The following is a description of a gene set: from publication Qiu S, He P, Fang X, Tong H, Lv J, Liu J, Zhang L, Zhai X, Wang L, Hu Z, Yu Y (PMID 29580160) Individuals fail to elicit protective antibody after hepatitis B vaccination remain at risk for hepatitis B virus infection. Analysis of the transcriptome of peripheral blood mononuclear cells (PBMCs) is essential to elucidate the characteristics of gene expression in non-responders. In this study, we enrolled seven responders who had received three injections and seven non-responders who had six injections of hepatitis B vaccine before. All the participants were then vaccinated with a three-dose boost regimen. Microarray analysis and Luminex assay were applied to examine mRNA expression and Th1/Th2/Th9/Th17/Th22/Treg cytokine and chemokine profiles in non-responders and responders. Differentially expressed genes in PBMCs of non-responders at 5 time points, i.e. pre-vaccination, 3<sup>rd</sup>, 7<sup>th</sup>, 28<sup>th</sup> day post the first dose vaccination and 7<sup>th</sup> day post the second dose vaccination indicated a dense network trend. Compared with responders, nine coding genes (BPI, DEFA1B, DEFA4, CEACAM8, MMP8, FOLR3, LTF, TCN1 and TKTL1) were significantly up-regulated in non-responders at all 5 time points, which could probably be the characteristic genes in hepatitis B vaccine non-responsiveness. Gene ontology analysis revealed that most of the DEGs were related with immune responses. Validation results of these genes using quantitative real-time polymerase chain reaction were mostly consistent with the results of microarray. Cytokine analysis demonstrated that IL-27 and CXCL12 concentrations in responders were significantly higher than non-responders on the 3<sup>rd</sup> day after the first dose and 7<sup>th</sup> day after the second dose of vaccination, respectively. No significant difference was observed in other cytokine and chemokine signatures between the two groups. In conclusion, our results revealed characteristic transcriptome and cytokine changes in hepatitis B vaccine non-responders after boost immunization. studied in species Homo sapiens Genes up-regulated in peripheral blood mononuclear cell non-responders vs responders in adults (<50) after exposure to Heptatitis B surface antigen vaccine (HBsAg), time point 0D Human Gene Set: QIU_PBMC_HEPTATITIS_B_SURFACE_ANTIGEN_AGE_UNDER50_NON_RESPONDERS_VS_RESPONDERS_0DY_UP, and this is the list of marker genes: TCN1, CRISP3, ABCA13, MS4A3, CAMP, OLR1, TKTL1, DEFA4, DNM1P46, LTF, FOLR3 (NCBI Gene Id 2352), BPI, RNASE3, DEFA1B, CPA3, ARG1, MMP8, CEACAM8 (NCBI Gene Id 1088), SLPI